The following is a description of a gene set: Reactome Pathway: Synthesis and processing of ENV and VPU The two viral membrane proteins, Env and the accessory protein Vpu, which are encoded by the same mRNA, are translated on the rough ER. All virion components need to traffic from their point of synthesis to sites of assembly on the plasma membrane. Env is an integral membrane protein. It is inserted cotranslationally into ER membranes and then travels through the cellular secretory pathway where it is glycosylated, assembled into trimeric complexes, processed into the gp41 and gp120 subunits by the cellular protease furin. part of: Assembly Of The HIV Virion species: Homo sapiens, and this is the list of marker genes: vpu, env, FURIN